The following is a description of a gene set: Mouse Gene Set: GOBP_NEGATIVE_REGULATION_OF_MITOTIC_CELL_CYCLE studied in species Mus musculus Any process that stops, prevents or reduces the rate or extent of progression through the mitotic cell cycle., and this is the list of marker genes: Prmt2 (protein arginine N-methyltransferase 2), Fhl1, Ctdsp1, Heca, Zwilch, Abraxas1 (BRCA1 A complex subunit), Rad17, Plk1, Rad9a, Crlf3, Cdca8, Bub1, Klhl22, Cts7, Chmp4c, Pinx1, Mtbp, Tipin, Dact1, Cenpe (NCBI Gene Id 229841), Taok2, Cdk5rap3, Mir26b, Dusp1, Rbm46, Ctdsp2, Trrap, Rad21, Lcmt1, Cdc73, Pcid2, Mad1l1, Cdkn2b, Nabp2, Inhba, Spc25, Trim35, Meioc, Brcc3, Kntc1, Slfn1, Bcl2, Fgfr3, Rps6, Nle1, Nae1, Ccl12, Psmg2 (NCBI Gene Id 75651), Cdk2ap2, Scrib, Ska3, Nuf2, Pten, Nabp1, Ezh2, Tom1l2 (NCBI Gene Id 72936), Stk33, Gen1, Btg3, Zw10, Aven, Chek2, Bmp4, Arhgap33os, Brsk1, Msh2, Rad50, Fancd2, Gjc2, Khdc3, Stk35, Cep192, Klf4, Nek11, Zwint, Donson, Zfp655, Brinp3, Pabir1, Btn2a2, Ndc80, Btg4, Dcun1d3 (NCBI Gene Id 72260), Gas1, Dlg1, Bmp7, Xrcc3, Mus81, Plk3, Fzr1, Tex14, Nme6, Ier3, Hus1b, Rbl2, Ccnb1, Nherf1 (NHERF family PDZ scaffold protein 1), Wac, Fbxo31, Taok3, Miip, E2f7, Mad2l1, Brinp1 (bone morphogenic protein/retinoic acid inducible neural specific 1), Zfp36l2, Brinp2, Setmar, Foxc1, Angel2, Zfyve19, Brca1, Rb1, Rpl24, Aurkb, Zc3h12d, Blm, Pkd2, Birc5, Eme2, D7Ertd443e, Atr, Kank2, Usp44, Rbbp8, Ttk, Mir26a-1, Nop53, Cdkn1c, Rfwd3, Prkdc, Dgkz, Mre11a (NCBI Gene Id 17535), Inip, Prpf4b (pre-mRNA processing factor 4B), Hnf4a (NCBI Gene Id 15378), Myo16, Ccng1, Ppp1r10, Mbtps1, Ccnb1-ps, Syf2, Spc24, Cdc20, Rps27l, Foxn3, Cacnb4, Stil, Etaa1, Mir26a-2, Foxo4, Trp53, Timp2, Vps4a, Mrnip, Eme1, Cdc6, Wee1, Pkmyt1, Taok1, Prap1, Ptprv, Cdkn1b, Gpr132, Tom1l1, Esr1, Haspin, Mad2l1bp, Rad9b, Ska1, Atm, Fbxo7, Bub3, Cdc14b (CDC14 cell division cycle 14B), Ptpn3, Dync1li1, Brd7, Bub1b, Tnf, Xpc, Trip13, Knl1, Creb3l1, Uimc1, Orc1, Spdl1, Cdkn1a, Zfp207, Acvr1, Zfp36l1, Ccnd1, Ctdspl, Chfr, Bard1, Ik, Rgcc (NCBI Gene Id 66214), Cdk1, Rpa2, Anapc15, Sde2, Fgfr2, Dtl (denticleless E3 ubiquitin protein ligase), Chek1, Gigyf2, Abl1, Egfr, Fam107a, Trex1, Trim39 (tripartite motif-containing 39), Tpr, Rbl1, Mbd4, Mbtps2, Fzd3, Babam1, Brcc3dc, Pml, Ints3, Ovol1, Incenp, Babam2, Jade1, Cdk5rap2, Rint1, Tpra1, Fbxo5, Nbn, Zfp830, Usp47, Ythdc2, Clspn, Gpnmb, Ppp2r3d, Apc, Atf2, Topbp1, Ticrr, Hus1, Anapc15-ps, Pdik1l, Map3k20, Ctnnb1